The following is a description of a gene set: species: Homo sapiens Human Gene Set: GSE34156_UNTREATED_VS_6H_NOD2_LIGAND_TREATED_MONOCYTE_UP Genes up-regulated in monocytes (6h): untreated versus muramyl dipeptide. human blood monocytes were isolated, activated and harvested at several timepoints In this study, we identified genes that were differentially expressed in human monocytes activated with eiter NOD2L and/or TLR2/1L. from publication Schenk M, Krutzik SR, Sieling PA, Lee DJ, Teles RM, Ochoa MT, Komisopoulou E, Sarno EN, Rea TH, Graeber TG, Kim S, Cheng G, Modlin RL (PMID 22447076), and this is the list of marker genes: LIMK1, NDEL1, NUDT8, TAPT1, IKBKG, LRRC8D, ELL, MGRN1, TULP3, ANXA3, UFSP1, NDUFB9, MAP2K2, PDE8B, NADSYN1, PRDM5, MIR202, RFNG, YAF2, RRBP1, VAPA, EID2, CCDC97 (NCBI Gene Id 90324), FKBP8, BMPR1A, SNX1, C1orf94, SDHAF3, TNFAIP3, BCL11A, ABRA, LAMTOR3, POLR2G (RNA polymerase II subunit G), UBE2A, ACY1, CNPY3, SEPTIN9, CDHR2, CDC42SE1, GDE1, PRDX6, NT5M, LHFPL2, TGFB1, RUNX3, TSEN54, PDK4, HPCAL1, PSTK, SPIN4, TMEM119, MRPS7, PARP16, SPTLC2, RNF215, SLC25A37, SLC35F4, GEMIN7, TOLLIP, PRDX1, ISCU, CD9, NDUFA10, RPS19BP1, UBQLN4, BST1, RHOD, VAPB, RXRA, MFGE8 (milk fat globule EGF and factor V/VIII domain containing), LPCAT1, PTPMT1, MTX1, FTH1, ATP6V1G1, DTNBP1, IRF5, SPON1, PTGES2, NAT9, HADH, GUF1, RARA, AKT1, GSTK1, ATOX1, HDHD5, TBKBP1, RNF157, MMP12, SLC22A4, ECM1, TBC1D7, CYB5B, LCP2, RAB20, TOM1, IRAK2, PKP2, LBP, UROS, CTNNB1, STRIP1, NMNAT3, PSTPIP1, DUSP7 (dual specificity phosphatase 7), CTDNEP1, PPDPF, MRPL44, CDC42EP3 (CDC42 effector protein 3), RFFL, DCAF1, MRPL36, CCDC57, PPIC, CPLX2, MINDY1, KDM6B, ZBTB7A, PRAM1, TOP1MT, IL1RL2, EFHC1, ZFAND3, PKDCC (NCBI Gene Id 91461), HMOX1, GRPEL1, NDUFA7, SAMD8, SARS2, ECHS1, RPIA, ZBTB3, GSTA3, UBTD1, ZFYVE9, DGKB, CEP131, HBQ1, NEBL, GSR, SLC8A2 (solute carrier family 8 member A2), GCLM, SGMS1, TMBIM1, PDLIM1, PTGS1, SSTR5, PPP1R13L, SSBP4, MT4, ITGA1, RAE1, PPT2, TST, PLIN2, TALDO1, LYN, SLC29A1, TJAP1, HSF1 (heat shock transcription factor 1), CD81, CEBPA (CCAAT enhancer binding protein alpha, NCBI Gene Id 1050), ARID3A, NRBF2, PAG1, SNAP47, TMEM154 (transmembrane protein 154)